The following is a description of a gene set: Genes down-regulated in HPIV3 (A549 cells, MOI: 2, 24hpi) Human Gene Set: BLANCO_MELO_HUMAN_PARAINFLUENZA_VIRUS_3_INFECTION_A594_CELLS_DN from publication Blanco-Melo D, Nilsson-Payant BE, Liu WC, Uhl S, Hoagland D, Møller R, Jordan TX, Oishi K, Panis M, Sachs D, Wang TT, Schwartz RE, Lim JK, Albrecht RA, tenOever BR (PMID 32416070) studied in species Homo sapiens Analysis of the transcriptional response to SARS-CoV-2 compared with other respiratory viruses, including MERS-CoV, SARS-CoV-1 (SARS), human parainfluenza virus 3 (HPIV3), respiratory syncytial virus (RSV), and IAV., and this is the list of marker genes: FGFR3, NPFF, SPC24, FCGBP, KRT4, SLC26A1, CERS4, ARHGEF16, ITGB2-AS1 (ITGB2 antisense RNA 1), WDR97, PLEKHH3, CRYM, SERPINF2, CLDN3, VWA5B2 (von Willebrand factor A domain containing 5B2), TYMSOS (NCBI Gene Id 494514), ATOH8, LGALS4, RAP1GAP, EFCAB12, ENHO, CCER2, SHC2, PRODH2, HOGA1, GOLGA2P7, EPHB3, C21orf58, A4GALT, HABP2, ZNF219, ZNF837, BCAM, WFDC21P, HSD17B14, PRODH, FBXO2, VMO1, NECAB2, MYL9 (myosin light chain 9), BCRP3, LLGL2, DBP, AKR1C1, CDC42BPG, TMEM191A, KIF12, ROM1, ARHGAP33 (NCBI Gene Id 93092), CHTF18, TLX2, HOXC13-AS, ZDHHC8BP, HSD17B8, NUDT16L1, BCAS1, ADH6, FAM86B3P, CHST13, SSTR5-AS1, FOXD2, CEBPA, GAL3ST1, GALNT9-AS1, RAB26, GPR35, FGFR4, ELN, TJP3, ANXA9, LMNTD2, MIR210HG, ABCC6, SLC29A4, AQP3, TIGD3, SELENBP1, RNF208, SSTR5, GPR162, MCF2L (NCBI Gene Id 80044), HSD17B1, SYNGR4, HR, AMBP, MYO1A (myosin IA), BIRC7, VWA1, H19, ARRB1, CACFD1, DIPK1B, SEMA6B, CAPS, CRB3, SNORA50C, HLA-DMB, CYP4F12, ADM5, DEGS2, CCN5, ANKS4B, NPW, HS3ST6 (heparan sulfate-glucosamine 3-sulfotransferase 6), IFITM10, LINC02593, TMEM37, VASN, CA9, H1-10-AS1, C6orf226, SERPINA6, LINC02870, HLA-DMA, RAB37, RERG, VPS37D, AMH, C9orf152, USH1C, TUBB4A, CAMSAP3, MROH6